Given this list of marker genes Anln, Trip13, Cdk1, Pcna, Nusap1, D17H6S56E-5, Cdk2, 2700099C18Rik, Dut, Fen1, Ccna2, Dna2, Mki67, Kpna2, Cdt1, Rpa1, Tk1, Top2a, Mcm7, Rb1, Cdc20, Sgo1 (NCBI Gene Id 98076), Rrm2, Kif2c, Lbr, Bub1, Hmgb2, Ccnb1, Ccne1, Asf1b, Dctpp1, Pttg1, Rrm1, E2f8, Kifc1, Cdca7, Stmn1, Mcm3 (minichromosome maintenance complex component 3), Hmgb3, Cdkn2c, Aurkb, Ezh2, Nsg1, Anxa8, Ncaph, Rad51, Ccnb2, Ube2t, Lig1, Rfc3, Smc2, Dbf4, Slbp, Prim1, Prc1, here is a description of the gene set: studied in species Mus musculus from publication Ishida S, Huang E, Zuzan H, Spang R, Leone G, West M, Nevins JR (PMID 11416145) We have used high-density DNA microarrays to provide an analysis of gene regulation during the mammalian cell cycle and the role of E2F in this process. Cell cycle analysis was facilitated by a combined examination of gene control in serum-stimulated fibroblasts and cells synchronized at G(1)/S by hydroxyurea block that were then released to proceed through the cell cycle. The latter approach (G(1)/S synchronization) is critical for rigorously maintaining cell synchrony for unambiguous analysis of gene regulation in later stages of the cell cycle. Analysis of these samples identified seven distinct clusters of genes that exhibit unique patterns of expression. Genes tend to cluster within these groups based on common function and the time during the cell cycle that the activity is required. Placed in this context, the analysis of genes induced by E2F proteins identified genes or expressed sequence tags not previously described as regulated by E2F proteins; surprisingly, many of these encode proteins known to function during mitosis. A comparison of the E2F-induced genes with the patterns of cell growth-regulated gene expression revealed that virtually all of the E2F-induced genes are found in only two of the cell cycle clusters; one group was regulated at G(1)/S, and the second group, which included the mitotic activities, was regulated at G(2). The activation of the G(2) genes suggests a broader role for E2F in the control of both DNA replication and mitotic activities. Genes up-regulated in MEF cells (embryonic fibroblast) after expression of E2F1 or E2F2. Mouse Gene Set: ISHIDA_E2F_TARGETS